The following is a description of a gene set: A large multisubunit complex which catalyzes protein degradation, found in eukaryotes, archaea and some bacteria. In eukaryotes, this complex consists of the barrel shaped proteasome core complex and one or two associated proteins or complexes that act in regulating entry into or exit from the core. studied in species Homo sapiens Human Gene Set: GOCC_PROTEASOME_COMPLEX, and this is the list of marker genes: USP14, PSME4 (proteasome activator subunit 4), PSMB7, VCP, PSMB10 (proteasome 20S subunit beta 10), PSMB2, PSMD7, PSMB5, PSMA7, PSMC2, PSMA8, UCHL5, TXNL1, PSMB3, DNAJB2, PSMC5 (NCBI Gene Id 5705), PSMD10, HSPB1, PSMD6, PSMC6, PSMD3, PSMD9, UBQLN4, PSMC1, PSMB1, PAAF1, PSMD4, PSMD2, PSMA6, PSMA4, RAD23A, ADRM1, UBE3C, UBQLN1, PRICKLE1, UBE3A, PSMD11, PSMA5, PSMD1, PSMD12 (proteasome 26S subunit, non-ATPase 12), PSMD8, ZFAND2A, PSMB6, PSMD14, PSMD5, RAD23B, SEM1, PSMC3, PSMA2, PSMA3, UBR1, ECPAS, IDE, PSMB11, PSMA1 (NCBI Gene Id 5682), PSME3 (proteasome activator subunit 3), PSME2, PSMB4, PSMF1, PSME1, PSMC4, PSMD13, PSMB8, PSMB9, ZFAND2B